Given this list of marker genes Osm (oncostatin M), Amer2, Tmx2, Slc7a15, Clic6, Bsn, Adamts15, Lrrc8d, Igdcc4, Foxn3, Plscr2, Kirrel1, Hexim1, Nhsl2, Baz2a, Mylk4, Plxna4, Evi2b, Rnd3, Tat, Mtcl2, Man1a, Arid1a, Vezf1, Bcl11b (NCBI Gene Id 78682), Cdc42ep4, Pea15a, Il2ra, Dcdc2a, Cplx1 (complexin 1), Gjb2, Abcg4, Gal3st3, Sypl2, Gm4984, Mybpc1, Sox13, Dlgap4, Ogt, Gdi1, Skint7, Rab6b, Capn1, Supt5, Pomk, Tmem144, Mobp, Inpp5a, Ppp1r1c, Sult5a1, Cpa4, Tmed7, Ranbp10, 4930558K02Rik, Mospd3, Ammecr1, Trim39, Srgap3, Snx12, Snhg11 (small nucleolar RNA host gene 11), Fgf9, Minar2, Ikzf3, Ier3, Mnat1, Pip4p1, Rlig1, Man2a1 (NCBI Gene Id 17158), Col4a4, Ctsb, Itsn1, Stk32b, Lbh, Lrp4, Lamc1, Nkx2-1, Stat2, Gdpd4, Dnajc5, Naa20, Zfp710, Slc35d1, Arf3, C5ar1, Trim66, Siglecl2, Gskip, Ark2c, Tmem101, Rnf150, Stard5, Vwc2, Ttbk2, Usp46, Glg1, Exph5, Igsf9b, 1110004F10Rik, Parvb, Supt16 (NCBI Gene Id 114741), Gmfb, Bcat1 (branched chain aminotransferase 1, cytosolic), Zc3h7a, 6430550D23Rik, Kcnj6, R3hdm1, Pdha2, Naa50, Trim67 (tripartite motif-containing 67), Lingo1, Rnf17, Actn1 (actinin, alpha 1), Ttc39d, Gpc6, Vapb, Rnf41, Pitpnb, Agap1, Cyp2b13, Sec22c, Entpd7, Mcu, Atp7a, Mlph, Sbk3, Gca, Prg4 (proteoglycan 4 (megakaryocyte stimulating factor, articular superficial zone protein)), Fbxw7, Fam219b, Ywhaz, Desi1, Hacd1, Otud7b, Zfp512, Fam76a, Fam219a, Prop1, here is a description of the gene set: studied in species Mus musculus Genes predicted to be targets of miRBase v22 microRNA mmu_miR_6916_5p in miRDB v6.0 with MirTarget v4 prediction scores > 80 (high confidence targets). from publication Chen Y, Wang X (PMID 31504780) Mouse Gene Set: MIR_6916_5P